Given this list of marker genes UMPS, MMACHC, MTRR (5-methyltetrahydrofolate-homocysteine methyltransferase reductase), CUBN, LMBRD1, MMADHC, PHGDH, MTR, DHFR, CBLIF, SLC19A1, PRDX1, FTCD, AMN, SLC46A1, WFS1, MTHFD1, HPRT1, SLC19A2, here is a description of the gene set: Anemia characterized by the presence of erythroblasts that are larger than normal (megaloblasts). species: Homo sapiens Megaloblastic anemia Human Gene Set: HP_MEGALOBLASTIC_ANEMIA